Given this list of marker genes FUNDC2, PRR11, PKM, TRPS1, PTBP3, UBXN7, SLC7A1, RABL6, IGSF5, RBM43, ZSCAN30, PDK4, VAMP3, NOL4L, EEIG1, GIT1, SEMA4D, KCNN3, DNAH2, MAP3K12, SLCO5A1, WDR47, ADSS2, P4HA1, SLC25A34, ZNF213, DICER1, RBL1, ARFGEF1, ANKRD13C (ankyrin repeat domain 13C), GYS1, OCLN, CLIC5, CS, TRPM1, HNRNPU, HECTD3, KIF11, FLNB, HECW2, SESN2, SMYD4, RAVER1, G6PD, RANBP3L, CCDC186, BRPF1, CLIC4, ADGRB2, SMARCD1, TUBA1C, SLC4A8, MICU3, TBC1D22B, CD40LG, ZNF827, FKBP5, GNPDA2, PIP4K2A, TBR1, SHPRH, SLC7A14, CD320, CTDNEP1, SEC22C, MECOM, CCNG1, MIPOL1, ACTMAP, DDR2, TBC1D10B (NCBI Gene Id 26000), MOSPD1, GABRA3, CA10, STMN2, SLC52A2, SPRY2, ABHD11, GRPR, CTNNA3, CUX1, EPCIP, CYP20A1, GALNT1, MYOCD, LAMC1, MYO9A, RBMS2, TFB1M, RBM47, CPEB1, here is a description of the gene set: from publication Chen Y, Wang X (PMID 31504780) studied in species Homo sapiens Human Gene Set: MIR122_5P Genes predicted to be targets of miRBase v22 microRNA hsa-miR-122-5p in miRDB v6.0 with MirTarget v4 prediction scores > 80 (high confidence targets).